The following is a description of a gene set: Human Gene Set: GOMF_NAD_TRANSMEMBRANE_TRANSPORTER_ACTIVITY studied in species Homo sapiens Enables the transfer of NAD from one side of a membrane to the other., and this is the list of marker genes: SLC25A51, SLC25A17, SLC25A53, SLC25A52, SLC25A47